The following is a description of a gene set: Human Gene Set: GOCC_KATANIN_COMPLEX studied in species Homo sapiens A complex possessing an activity that couples ATP hydrolysis to the severing of microtubules; usually a heterodimer comprising a catalytic subunit (often 60kDa) and a regulatory subunit (often 80 kDa)., and this is the list of marker genes: KATNA1, KATNAL2, KATNB1, KATNAL1, KATNBL1